The following is a description of a gene set: Mouse Gene Set: MIR_142A_5P from publication Chen Y, Wang X (PMID 31504780) studied in species Mus musculus Genes predicted to be targets of miRBase v22 microRNA mmu_miR_142a_5p in miRDB v6.0 with MirTarget v4 prediction scores > 80 (high confidence targets)., and this is the list of marker genes: Sgce, Hp1bp3, Ube2a, Elavl4, Tns1 (tensin 1), Ccng2, Fam114a2, Zfr, Ark2c, Robo1, Fbxo45, Kif15, Pcgf3, Pik3ca, Zfpm2, Arhgap11a, Mdga2, Pcdhb3, Dpy19l3 (NCBI Gene Id 233115), Ube4a, Gopc, Ptpn4, Macf1, Tbl1xr1, Vav3, Il17d, Med14, Septin2, Lhfpl3, Cfap52, Acta2, Il22b, Ppp1r42, Paip1, Wwp1, Set, Gngt1, Mlh3, Rgs17, Zfp275, A830018L16Rik, Tmx3, Plk1, Csmd3, Otud4, Kctd14, Dynlt1c, Pno1, Tut4, Toe1, Unc80, Prpf4b, Actc1 (actin, alpha, cardiac muscle 1), Ttc41, Trip13, Ranbp1, Nedd1 (neural precursor cell expressed, developmentally down-regulated gene 1), Ldb2, Cdk17, Appl2, Dio2, Usp39, Ckap2l, Or5m3b, Tiam1, Mcmdc2, E130308A19Rik, Or51l4, Trp63, Lmx1a, Capn7, Tmem183a, Cntn1, Gtf2a1, Ncapg2, Skp2, Tmem68, Nexmif (NCBI Gene Id 97590), Dnajc7, Atxn7l2, Zc3h12c, Dlg2, S2bpcox16, Virma, Stk35, Mdh1, Pi15, Prkg1, Sgms1, Spire1, Fam199x, Rilpl2, Mical2 (microtubule associated monooxygenase, calponin and LIM domain containing 2), Gdnf, Atp13a3, Sh3rf3, Iqsec1, Mtmr10, Slain1, Usp45, Uba3, Rap1a, Synj1, Mbd3l1, Gpr119, Scml2, Golga1, Adamts5, Kif13a, Cnep1r1, Cert1, Rhoa, Hook3, Prpf40a, Dnajc25, Pgm3, Cox16, Adamts1 (NCBI Gene Id 11504), Adgrb3, Atp1b1, Eaf2, Actn4, Orc3, Armc8, Gpr75, 9230112D13Rik, Rexo1, Necab1, Spag9, Eif4a2, Traf3ip3, Usp13, Socs1, Acbd5, Srsf6, Cbln4, Ghr, Baz2a, Kras, Slc16a9, Igf2bp3, Usp9x, Abca1, Maml1, Krtap20-2, Zfp770, D6Wsu163e, Lrp12, Klrb1b, Hdlbp, Fam131b, Etv1, Zbtb37, Ywhah, Clint1, Lpp, Aard, Garem1, Slc31a2, Bicd1, Etfdh, Ppip5k2, 1700010I14Rik, Selenot, Map4k3, Mycn, Trim2, Epas1, Arhgef40, Ccdc71l, Dmd, Lrp2, Ptpn2, Nr1d2, Caprin2, Fgf12, Tmem245, Fancm (Fanconi anemia, complementation group M), Vmp1, Triqk, Gorasp1, Rnf146, Kif5c, Acadsb, Trdmt1, Brd1, Cdc42ep4, Arap2, Brdt, Rbm24, Hycc1, Efcab14, Eeig2 (NCBI Gene Id 69782), Ube2d1, Vmn1r51, Rsf1, Tbc1d9, Lrrc58, Mtg1, Tenm3, Clec2d, Cdc37l1, Pigw, Commd2, 2410002F23Rik, Rnh1, Npat, Dynlt1b, Camsap2 (NCBI Gene Id 75184), Tafa1, Emc4, Xpr1, Arid2, Vrk1, Hhip, Zfp503, Tdo2, Vps54, AI467606, Fcho2, Fam91a1, Mmgt1, Hipk1, Klf11, Stau1, Nck2, Hnrnph3, Rag1, Cul4a, Btf3l4, Pip5k1b, Taf3, Ndfip2, Dynlt1f, Nkx3-1, Zxdb, Ankib1, Cbx3, Rhoc, Lgals8, Cep57, Fign, Zfpl1